Given this list of marker genes Epha4, Abl1, Tyrobp, Ptn, Apoe, Cx3cr1, Fxr1, Ager, App, Prnp, Ppp1r9a, Adora1, 2510002D24Rik, Fam107a, here is a description of the gene set: studied in species Mus musculus Any process that stops, prevents or reduces the frequency, rate or extent of long-term synaptic potentiation. Mouse Gene Set: GOBP_NEGATIVE_REGULATION_OF_LONG_TERM_SYNAPTIC_POTENTIATION